Given this list of marker genes BRD10, SAMSN1, SATB2, HNRNPH3, NFIA, MARCHF1, CEP135, DOCK9, ATAD3C, OGT, CISD3, PREX2, ZBTB10, KAT6A, PDE6C, LONRF1, CCSAP, CAPN7, TGIF1, TMEM117, ADAM12, EIF3J, DCSTAMP, SLAIN2, DCAF4L2, RAP1A, STMN2, CHIC1 (NCBI Gene Id 53344), LRRK2, BLOC1S5, KIF13A, KPNA2, NFAT5, SPCS3, SIRT5, DDR2 (NCBI Gene Id 4921), NLGN1 (neuroligin 1), ATP2A2, NCAM2, DEFB110, DNER, NAA15, SATB1, FOXO3, ATP2B2, PLEKHA1, LARS1 (NCBI Gene Id 56885), AREL1, ANP32E, KCNH7, FLRT3, AFDN, SIX4, PCNX4, ZNF704, ZC3H12C, MTOR, KICS2, HYCC2, RIOK1, POGLUT1, SMG1, RAB12, METRN, THSD7A, DACH1 (NCBI Gene Id 1602), CDK14, WASHC5, MEX3D, GNGT1, TBC1D24, RORA, TTLL12, TAL1, NETO1, VNN1, PCYOX1, FBXW11, FAM13B, DPY19L1, TMED4, HACD2, TMPO, TMSB4X, CDYL, RNF149, SV2A, KIFC3, LSM14A, PPP1R14C, PCDHB6, CSH2, RIMS2, EPHA6, FNTA, ZBTB20, CALR, PLAC8, CGNL1, CNTN4, RGS2, TENT2, ARFGEF1, FERMT1, PTPN4, PIK3C2A, NAAA, CDC73, HTR1B, PHF2, HHLA2, ZNF225, HERC3, CXCL1, OGFRL1, PALM2AKAP2, ZSWIM6, PCDH10, VASH2, GH2, GPBP1, BCAR1, MYSM1, UTP3, SAMD9L, DTL, MAP3K2, KCNA4 (potassium voltage-gated channel subfamily A member 4), CCNL1, FBXO36, IQCK, BCLAF3, NUP50, SMAD5, PAN3, PPM1A, ZZZ3, KATNBL1, CNMD, TBC1D19, here is a description of the gene set: Genes predicted to be targets of miRBase v22 microRNA hsa-miR-5584-3p in miRDB v6.0 with MirTarget v4 prediction scores > 80 (high confidence targets). Human Gene Set: MIR5584_3P from publication Chen Y, Wang X (PMID 31504780) studied in species Homo sapiens